The following is a description of a gene set: studied in species Homo sapiens Selected genes implicated in metastasis and epithelial-to-mesenchymal transition (EMT) which were up-regulated in MDA-MB-231 cells (breast cancer) upon knockdown of SKI by RNAi. c-Ski is an important corepressor of transforming growth factor-beta (TGF-beta) signaling through its ability to bind to and repress the activity of the Smad proteins. It was initially identified as an oncogene that promotes anchorage-independent growth of chicken and quail embryo fibroblasts when overexpressed. Although increased Ski expression is detected in many human cancer cells, the roles of Ski in mammalian carcinogenesis have yet to be defined. Here, we report that reducing Ski expression in breast and lung cancer cells does not affect tumor growth but enhances tumor metastasis in vivo. Thus, in these cells, Ski plays an antitumorigenic role. We also showed that TGF-beta, a cytokine that is often highly expressed in metastatic tumors, induces Ski degradation through the ubiquitin-dependent proteasome in malignant human cancer cells. On TGF-beta treatment, the E3 ubiquitin ligase Arkadia mediates degradation of Ski in a Smad-dependent manner. Although Arkadia interacts with Ski in the absence of TGF-beta, binding of phosphorylated Smad2 or Smad3 to Ski is required to induce efficient degradation of Ski by Arkadia. Our results suggest that the ability of TGF-beta to induce degradation of Ski could be an additional mechanism contributing to its protumorigenic activity. Human Gene Set: LE_SKI_TARGETS_UP from publication Le Scolan E, Zhu Q, Wang L, Bandyopadhyay A, Javelaud D, Mauviel A, Sun L, Luo K (PMID 18451154), and this is the list of marker genes: CD44, AKR1C3, ADAMTS1, CDH11, NRP1, SNAI2, NRG1, SPHK1, AGR2, ITGB4, HMGA2, S100A4, ENPP2, KRT19, SERPINE2, ADAMTS6, HSPB8